Given this list of marker genes Chp1, Nagpa, Acer2, Alg13, Gba1, St6galnac4, Galnt18, B4galnt1, Vegfb, Extl3, Pigb, Ramp1, Alg2 (ALG2 alpha-1,3/1,6-mannosyltransferase), Mgat5b, Dolk, St6gal1, Rpn2, B3gnt3, Ost4, Alg8, C1galt1c1, Mgat4e (MGAT4 family, member E), B3galt1, B3gnt7, Tet1, Ces2a, Tmtc4, Galntl6, Tmtc3 (transmembrane and tetratricopeptide repeat containing 3), Pmm2, B4galt1, Fut10, St8sia4, Mgat4a, Fktn, Fut11, Slc4a10, Poglut1, 4930568D16Rik, Aqp11, Ggta1, Mlec, Krtcap2, Npc1, B3galt4, Ext2, Ogt, Dpy19l3, B3gnt2, Galnt13, Alg1, Fut9, Ube2j1, 4930402F06Rik (RIKEN cDNA 4930402F06 gene), Alg6, B3gnt6 (UDP-GlcNAc:betaGal beta-1,3-N-acetylglucosaminyltransferase 6), St6galnac5, Fkrp, Rft1, Rxylt1, Nans, B4galt3, Fut7, Ostc, Mgat4d, 6430550D23Rik, Gcnt3, B3galt6, St3gal1, Fut1, Psen1 (NCBI Gene Id 19164), Tusc3, Gfpt2, Gorasp1, Man1a, Mgat4b, Mgat4f, Fut2, Arfgef1, Galnt4, Tet3, Alg3, Pomgnt2, Plod3, Galnt7, Gcnt4, Stt3a, Man2a1, B4galt4 (UDP-Gal:betaGlcNAc beta 1,4-galactosyltransferase, polypeptide 4), Dtwd2, Magt1, St8sia3, Mgat2, Trak2, B3galt2, Extl1, Galnt16, Crppa, Gba2, St6galnac3 (ST6 (alpha-N-acetyl-neuraminyl-2,3-beta-galactosyl-1,3)-N-acetylgalactosaminide alpha-2,6-sialyltransferase 3), Galnt9, St8sia1, B3gnt9, Mgat5, B4galnt2, Ccdc134, Slc51b, Serpina1b, Galnt6, A3galt2, Ddost, Cog7, St6galnac1, B3glct, Alg10b, Dad1, Gcnt1, Alg12, Pgm3, Pofut1, Cog5 (NCBI Gene Id 97838), St6galnac2, Tmem59, Entpd5, Cog4, Alg11, Il15 (interleukin 15), Galnt10, B3galnt2, Edem3, Cwh43, Large1, B3gnt5, Poglut3, St3gal5, Uggt1, Galnt1, Pofut2, Lmf1, B4galt7, Dpm1, St3gal6, Alg14, Fuom, Large2, Sec1, Galnt14, B3gat1, Man2a2, Cog2, Stt3b, Xxylt1, Mogs, B3gnt4, Uggt2, Man1b1, St6gal2, Dpy19l1, B3galnt1 (NCBI Gene Id 26879), Tmtc1, Dolpp1, Gxylt2, Cog3, Cds2, B3gat3, Serpina1a, C1galt1, Pmm1, Pate6, Mgat4c, Tmem260, Galnt5, B4galt6, Galnt3, Pomt1, Pomgnt1, Golga2, B3galt5, Atp4b, Poglut2, Tmem258, B4galt2, Nanp, B3gat2, Cog1, B4gat1, Galntl5, Alg5, Tmtc2, Galnt15, Gmppb, Fut4, B3galt9, Gbgt1, St6galnac6, Cog6, St8sia6, Grm7, Gcnt7, A4gnt, Mgat1, Dpagt1, Slc35c1, Abca2 (ATP-binding cassette, sub-family A member 2), Alg9, Derl3, Gcnt2, Oga, Fut8, St8sia5, Trip11, Tet2, Pomk, Galnt12, Abo, Mgat3, Galnt11, Dpm2, St3gal2, Pomt2, Galnt2, Tmem165, B3gnt8, Ext1, Gmppa, St3gal4, Gfpt1, Slc35c2, St3gal3, Dpm3, Rpn1, Gxylt1 (NCBI Gene Id 382997), Nus1, Glt6d1, Galnt17, Cln5, St8sia2, Srd5a3, Dhdds, Slc39a8, Cog8 (NCBI Gene Id 97484), Frey1, Man1a2, B4galt5, Eogt, here is a description of the gene set: studied in species Mus musculus Mouse Gene Set: GOBP_GLYCOSYLATION The covalent attachment and further modification of carbohydrate residues to a substrate molecule.